Given this list of marker genes TERC, GAR1, SNRPE, PTGES3, TEP1, SNRPB, SMG5, HNRNPC, SNRPD3, ACD, TERT, HNRNPU, LSM11, NVL, NAT10, DKC1, GNL3L, SMG7, NHP2, SMG6, NOP10, WRAP53, here is a description of the gene set: studied in species Homo sapiens Human Gene Set: GOCC_TELOMERASE_HOLOENZYME_COMPLEX Telomerase is a ribonucleoprotein enzyme complex, with a minimal catalytic core composed of a catalytic reverse transcriptase subunit and an RNA subunit that provides the template for telomeric DNA addition. In vivo, the holoenzyme complex often contains additional subunits.